Given this list of marker genes Kit, Sirt2, Pten, Ltbp4, Apc, Braf, Pinx1, Msh2, Ptch1, Tlr2, Tnk1, Ndrg2, Nrbp1, B3gnt6, Stat3, Mlh1, Msh6, Stk11, Rcbtb2, Nlrp6, Men1, here is a description of the gene set: Mouse genes annotated to increased gastrointestinal tumor incidence (MP:0010279) retrieved from the Mouse Genome Informatics database via MouseMine Mouse Gene Set: MP_INCREASED_GASTROINTESTINAL_TUMOR_INCIDENCE species: Mus musculus from publication Motenko H, Neuhauser SB, O'Keefe M, Richardson JE (PMID 26092688)